Given this list of marker genes ANO5, SLC38A2, CASZ1, MTCL2, FIBCD1, EOLA1, CELF1, PSME3IP1, INHBB, TESMIN, F2RL3, DCUN1D4, NCAPG, TAF8, PIK3R1, STX16, TFAP4, CD2AP, SNED1, TIFAB, KCNA6, SH2B1 (NCBI Gene Id 25970), PPME1 (protein phosphatase methylesterase 1), BSN, ANKH, SLAIN2, LHX6, GRAMD1B, DMRT2, IL20RA, ARK2N, ADGRG5, ZNF346, JADE3, NKAIN2, STMN4, SLC4A8, DYRK1A, ARRB1, MRAP, CDK14, RNF222, TANGO6, B4GALNT3, KLHL29, TMEM178B, COL5A1, PRKCA, SLC26A7, YPEL1, EVC, PDXK, FBXL7, PTCH1, KALRN, GREM1, QRICH1, MEGF8, SLC10A3, SH3KBP1, AMZ1, DSC1, TSC1, BACH2, here is a description of the gene set: studied in species Homo sapiens Human Gene Set: MIR6744_3P Genes predicted to be targets of miRBase v22 microRNA hsa-miR-6744-3p in miRDB v6.0 with MirTarget v4 prediction scores > 80 (high confidence targets). from publication Chen Y, Wang X (PMID 31504780)